The following is a description of a gene set: studied in species Homo sapiens Catalysis of the reaction: a carboxylic ester + H2O = an alcohol + a carboxylic anion, where the carboxylic chain has 8 or fewer carbon atoms. Human Gene Set: GOMF_SHORT_CHAIN_CARBOXYLESTERASE_ACTIVITY, and this is the list of marker genes: ABHD15, SIAE, ABHD3, ABHD2, ABHD1 (abhydrolase domain containing 1), CEL